Given this list of marker genes Mtmr14, Clic5, Cop1 (COP1, E3 ubiquitin ligase), Tgfb1i1 (NCBI Gene Id 21804), Lcorl, Cdyl, Timm10b, Tmem231, Zc3h11a, Akr1c13, Stat3, Ppp4r4, Nfs1, Macf1, Pcdh19, Dusp16, Fam168b, Rundc3b, Trip4, Mbnl3, Zfp711 (NCBI Gene Id 69243), Trpc1 (NCBI Gene Id 22063), Lsm6, Pik3ca, Iqsec3, Fyco1, Dcx, Amd2, Mtpn, Itgb1, Rbpj, Urb1, Mras, Dyrk1a, Abhd5, Cav1, Pxk, Wdfy2 (NCBI Gene Id 268752), Amd1, Mef2c, Hcar2 (NCBI Gene Id 80885), Picalm (phosphatidylinositol binding clathrin assembly protein), Gns, Nrcam, Oxsr1, Kdm4d, Rbm45, Pnisr, Zfp148, Npy1r, Lpin2 (lipin 2), Synj1, Npepps, Bloc1s6, Thbd, Tnfaip1, Pdpk1, Rnf111, Nsd2, Zfp819, Septin11, Sox5 (NCBI Gene Id 319649), Rc3h2, Zfp706, Ythdc1, Kirrel3, Iffo2, Scn1a, Cry2, Bltp3a, Zc3h6, Rbms1, Rapgef2, Thnsl2, Egr3, Erfe, Tshz3, Srrt, Pou2f1, Smurf2, Rab28, Acp1, Dhodh, Enah, Slc25a12 (NCBI Gene Id 99450), Gpatch2l, Col11a1, Rad51d, here is a description of the gene set: Mouse Gene Set: MIR_1190 Genes predicted to be targets of miRBase v22 microRNA mmu_miR_1190 in miRDB v6.0 with MirTarget v4 prediction scores > 80 (high confidence targets). from publication Chen Y, Wang X (PMID 31504780) species: Mus musculus